The following is a description of a gene set: Any process involved in the maintenance of an internal steady state of copper ions within an organism or cell. species: Homo sapiens Human Gene Set: GOBP_COPPER_ION_HOMEOSTASIS, and this is the list of marker genes: ANKRD9, CCDC22, SLC30A10, SCO1, PRNP, APP, SLC31A1, ARF1, COX10 (cytochrome c oxidase assembly factor heme A:farnesyltransferase COX10), XIAP, CP, PRND, SCO2, SLC31A2, ABCB6, CUTC, ATOX1, COX19, ATP7B, COMMD1, ATP7A, MT2A